Given this list of marker genes Slc6a8, Gpc1, Crlf1, Slit2, Lgals1, Col5a3, Col5a1, Lum, Thbs1, Plod2, Lama3, Vegfc, Plaur, Loxl1, Itgav, Vcam1, Grem1, Tgfbi (NCBI Gene Id 21810), Mylk, Adam12, Col6a2, Gem, Fgf2 (NCBI Gene Id 14173), Mmp2, Postn, Ccn1, Fbn2, Gas1, Pvr, Lamc2, Tnfrsf11b, Oxtr, Lama1, Lrp1, Cdh11, Col6a3, Lamc1, Fstl1, Foxc2, Fas, Abi3bp, Timp3, Anpep, Sfrp1, Snai2, Msx1, Nt5e, Igfbp3, Comp, Edil3, Itga2, Tpm2, Tagln, Pmepa1, Tpm1, Inhba, Tnfaip3, Pfn2, Sat1, Cxcl12, Spock1, Dcn, Ntm, Fstl3, Itgb5, Sdc1 (NCBI Gene Id 20969), Slit3, Tpm4, Pcolce, Cadm1, Thbs2, Aplp1, Il6, Sgcd, Sparc, Col8a2, Fmod, Gpx7, Fzd8, Calu, Efemp2, Notch2, Capg, Gm21451 (NCBI Gene Id 100862072), Ppib, Tnc, Ccn2, Col4a2, Cdh6, Dst, Itga5, Fap (NCBI Gene Id 14089), Nnmt, Col16a1, Glipr1, Cap2, Rgs4, Wnt5a, Wipf1, Prrx1, Vegfa, Dkk1, Thy1, Timp1, Eno2 (enolase 2, gamma neuronal), Col3a1, Mmp3, Vcan, Id2, Flna, Tnfrsf12a, Pmp22, Fbln2, Tgfbr3, Lrrc15, Pcolce2, Itgb3, Gadd45b (growth arrest and DNA-damage-inducible 45 beta), Copa, Pdlim4, Col4a1, Col5a2, Qsox1, Fbn1, Bdnf, Gadd45a (NCBI Gene Id 13197), Bmp1, Ecm2, Lama2, Cdh2, Fn1, Tgm2 (NCBI Gene Id 21817), Serpine1, Mest, Itgb1, Rhob, Sgcb, Myl9, Pdgfrb, Col12a1, Spp1, Plod1, Mcm7, Colgalt1, Sfrp4 (secreted frizzled-related protein 4), Matn3, Ptx3, Cxcl15, Ecm1, Col7a1, Fbln1, Eln, Cald1, Acta2, Dab2, Plod3, Pthlh, Serpinh1 (serine (or cysteine) peptidase inhibitor, clade H, member 1), Il15, Mmp14, Gja1, Basp1, Lox, Col1a2 (NCBI Gene Id 12843), Scg2, Jun, Bgn, Cxcl5, Igfbp2, Vim, Mfap5, Nid2, Fuca1, Mgp, Tgfb1, Fermt2, Sntb1, Fbln5, Htra1, Col1a1, Igfbp4, Tfpi2, Emp3, Col11a1, P3h1, Areg, Serpine2, Sgcg (sarcoglycan, gamma (dystrophin-associated glycoprotein)), Matn2, Dpysl3, Magee1, Cthrc1, Cd44, Sdc4, here is a description of the gene set: Mouse Gene Set: HALLMARK_EPITHELIAL_MESENCHYMAL_TRANSITION Mouse genes annotated to HALLMARK_EPITHELIAL_MESENCHYMAL_TRANSITION based on orthology mappings provided by the Alliance Genome Consortium from publication Howe DG, Blake JA, Bradford YM, Bult CJ, Calvi BR, Engel SR, Kadin JA, Kaufman TC, Kishore R, Laulederkind SJF, Lewis SE, Moxon SAT, Richardson JE, Smith C (PMID 30224793) studied in species Mus musculus